Given this list of marker genes EPAS1, CYBRD1, PICALM, SLC40A1, BMP6, SOD2, BTBD9, HAMP, SLC11A1, RHAG, IREB2, HMOX1, B2M, FECH, FBXL5, SLC11A2, NEO1, HJV, TMPRSS6, EIF2AK1, TF, HFE, HEPH, TFR2, EPB42, HYAL2, TFRC, NAGLU, here is a description of the gene set: Human Gene Set: GOBP_MULTICELLULAR_ORGANISMAL_LEVEL_IRON_ION_HOMEOSTASIS A chemical homeostatic process involved in the maintenance of a steady state level of iron within extracellular body fluids, such as blood, xylem or phloem, of a multicellular organism. This is distinct from maintenance of cellular homeostasis, which occurs within a cell. species: Homo sapiens